Given this list of marker genes Tada2a, Map3k7, Pole3, Tada3, Zzz3, Sgf29, Pole4, Kat2a, Wdr5, Mbip, Kat14, Yeats2, Dr1, Kat2b, here is a description of the gene set: studied in species Mus musculus A chromatin remodeling complex that regulates transcription via acetylation primarily of nucleosomal histones H3 and possibly H4. Shares the histone acetylation (HAT) module of GCN5/PCAF-ADA2-ADA3-SGF29 (or orthologs) with the related SAGA complex . Contains HAT subunits GCN5 or PCAF in a mutually exclusive manner. In addition to the HAT module contains DR1/NC2B, KAT14, MBIP, WDR5, YEATS2 and ZZZ3 or orthologs. Also regulates the activity of non-histone targets and orchestrates mitotic progression by regulating Cyclin A degradation through acetylation. Mouse Gene Set: GOCC_ATAC_COMPLEX